The following is a description of a gene set: Any process that contributes to cytokine production by a mast cell. Mouse Gene Set: GOBP_MAST_CELL_CYTOKINE_PRODUCTION studied in species Mus musculus, and this is the list of marker genes: Kit, Rasgrp1, Bcl6, Fcer1g, Nr4a3, Syk, Rabgef1, Hmox1, Fcer1a